Given this list of marker genes Antkmt, Eef2kmt, Atpsckmt, Vcpkmt, Setd2, Etfbkmt, here is a description of the gene set: Mouse Gene Set: GOBP_PEPTIDYL_LYSINE_TRIMETHYLATION The methylation of peptidyl-lysine to form peptidyl-N6,N6,N6-trimethyl-L-lysine. species: Mus musculus